Given this list of marker genes NLRP6, IL18RAP (NCBI Gene Id 8807), AKT1, CYLD, TICAM2, IL18R1, PIK3R1, CASP4, PDGFB, IL18, here is a description of the gene set: studied in species Homo sapiens The series of molecular signals initiated by interleukin-18 binding to its receptor on the surface of a target cell, and ending with the regulation of a downstream cellular process, e.g. transcription. Human Gene Set: GOBP_INTERLEUKIN_18_MEDIATED_SIGNALING_PATHWAY